Given this list of marker genes CSNK1A1, PPP2R5E, AMER1, GSK3B, PPP2R5C, PPP2CA, PPP2CB, AXIN1, PPP2R5A, PPP2R5D, APC, PPP2R1A, PPP2R1B, PPP2R5B, here is a description of the gene set: part of: Signaling by AMER1 mutants AMER1/WTX is a known component of the destruction complex and interacts directly with beta-catenin through the C-terminal half. siRNA depletion of AMER1 in mammalian cells stabilizes cellular beta-catenin levels and increases the expression of a beta-catenin-dependent reporter gene, suggesting that AMER1 is a tumor suppressor gene. Consistent with this, nonsense and missense mutations that truncate AMER1 and result in loss of the beta-catenin binding region have been identified in Wilms tumor, a pediatric kidney cancer. studied in species Homo sapiens Reactome Pathway: Truncations of AMER1 destabilize the destruction complex